The following is a description of a gene set: part of: Developmental Cell Lineages <p>The pancreas is a combined endocrine and exocrine gland that develops from an outgrowth of the primitive foregut and is closely associated with the upper duodenum (Liggitt and Dintzis, “Pancreas”, pp. 241-250). The exocrine pancreas, which comprises more than 95% of the pancreas mass, consists of lobules formed by tubuloacinar glands that are built by two main cell types: acinar cells, which synthesize and secrete digestive enzymes, and ductal cells, which line the ducts extending throughout the pancreas to the duodenum. A third cell type, centroacinar cells, is rare and has been characterized in mouse, but human studies have been inconclusive (Liggitt and Dintzis, “Pancreas”, pp. 241-250). The majority of single-cell omics data is restricted to pancreatic Langerhans islet cells due to difficulties in maintaining the integrity of ductal and acinar cells during pancreas dissociation.</p><p>During embryonic development, primary multipotent pancreatic progenitor cells (MPCs) that originate from the definitive endoderm-derived foregut endoderm, form ventral and dorsal pancreatic buds. All adult pancreatic cell types are derived from the MPCs.</p><p>Acinar cells are large pyramidal secretory epithelial cells that surround the lumen, thus forming an acinus (Liggitt and Dintzis, “Pancreas”, pp. 241-250). Acinar cells have prominent endoplasmic reticulum and Golgi networks, and their cytoplasm contains a large number of secretory zymogen granules, filled with different digestive enzymes, that are clustered in the vicinity of the apical surface (Liggitt and Dintzis, “Pancreas”, pp. 241-250). At the surface of the lumen, acinar cells are attached by apical tight junctions, while their basal surface is associated with the basal lamina (Liggitt and Dintzis, “Pancreas”, pp. 241-250). Centroacinar cells, characterized in rodents, are clear-staining spindle-shaped cells continuous with the lumen of intercalated pancreatic ducts (Liggitt and Dintzis, “Pancreas”, pp. 241-250).</p><p>Ductal epithelial cells line the pancreatic ducts in a single layer, changing the shape as ducts increase in size from cuboidal, through low columnar, to high columnar epithelium (Liggitt and Dintzis, “Pancreas”, pp. 241-250). Ductal epithelial cells may have cilia or microvilli on their apical surface (Liggitt and Dintzis, “Pancreas”, pp. 241-250). Besides ductal epithelial cells, main pancreatic ducts sometimes include goblet cells (Liggitt and Dintzis, “Pancreas”, pp. 241-250).</p><p>Either acinar or ductal cells are thought to give rise to pancreatic ductal adenocarcinoma (PDAC). Ductal cell-derived PDAC is thought to be more aggressive and is characterized by activating KRAS mutations and loss-of-function of TP53, FBXW7 or PTEN. Acinar cell-derived PDAC is thought to have a slower progression, and to frequently present as pancreatic intraepithelial neoplasia.</p> Reactome Pathway: Developmental Cell Lineages of the Exocrine Pancreas species: Homo sapiens, and this is the list of marker genes: LAMA1, COL3A1, COL5A3, LAMB2, FGF7, FGF4, FN1, FGF2, COL27A1, LAMA5, LAMB3, LAMC3, LAMC1, LAMA2, COL11A2, LAMB1, COL11A1, LAMA3, FGF10, COL2A1, EGF, COL24A1, LAMC2, COL1A2, COL5A2, COL5A1, COL1A1, VTN, LAMA4